Given this list of marker genes GFPT2, GFPT1, GNPNAT1, AMDHD2, UAP1, PGM3, RENBP, NAGK, here is a description of the gene set: species: Homo sapiens UDP-acetylglucosamine acts as a donor for the first two steps of the N-glycan precursor biosynthesis pathway, and is later used as a substrate for further modifications after the precursor has been attached to the protein. It is synthesized from fructose 6-phosphate, glutamine, acetyl-CoA, and UTP in four steps. Reactome Pathway: Synthesis of UDP-N-acetyl-glucosamine part of: Synthesis of substrates in N-glycan biosythesis